The following is a description of a gene set: The Y-shaped region of a nuclear replicating DNA molecule, resulting from the separation of the DNA strands and in which the synthesis of new strands takes place. Also includes associated protein complexes. Human Gene Set: GOCC_NUCLEAR_REPLICATION_FORK species: Homo sapiens, and this is the list of marker genes: HELB, POLD1, WDHD1, RPA4, PCNA, MMS22L (NCBI Gene Id 253714), SMARCA5, POLA1, TONSL, EME1, SMARCAL1, POLA2, PARP1, RPA3, CAMSAP3, TIMELESS, XPA, PRIM1, MUS81, TIPIN, PLRG1, SMARCAD1, BAZ1B, MCM10, ZRANB3, PRPF19, CARM1, ZMIZ2, POLD4, ERCC5, RPA1, EME2, CDC5L, TREX1, BCAS2, PRIM2, POLD3, MCM3, ETAA1, RPA2, POLD2